Given this list of marker genes SDHB, SDHAF2, NF1, SDHC, SDHD, here is a description of the gene set: Human Gene Set: HP_GLOMUS_JUGULAR_TUMOR studied in species Homo sapiens Glomus jugular tumor